Given this list of marker genes KDM4B, PLEK, SEZ6L, PLEKHA4, KIAA2013, CRTC3, ASB10, TLR1, SPATA31E1 (NCBI Gene Id 286234), PHLDB1, RHOT1 (NCBI Gene Id 55288), MAML1 (NCBI Gene Id 9794), IGLJ3, PPP1R15A, SPATA21, GPR17, H2BC11, MARVELD1, MYG1, LINC00242, SLC26A9, PPARD (peroxisome proliferator activated receptor delta), SLC45A1, H2AC11, TMEM33, AHNAK, NECAP2, ARHGAP10, EIF3A, PLEKHG4B, EPHA2, ZNF853, AOC1 (NCBI Gene Id 26), AHNAK2, PKDCC, ARF6, TSFM, MED25, BATF2, NOS3, here is a description of the gene set: from publication Figueroa ME, Lugthart S, Li Y, Erpelinck-Verschueren C, Deng X, Christos PJ, Schifano E, Booth J, van Putten W, Skrabanek L, Campagne F, Mazumdar M, Greally JM, Valk PJ, Löwenberg B, Delwel R, Melnick A (PMID 20060365) studied in species Homo sapiens Cluster 3 of aberrantly hypomethylated genes in blasts from AML (acute myeloid leukemia) patients. We hypothesized that DNA methylation distributes into specific patterns in cancer cells, which reflect critical biological differences. We therefore examined the methylation profiles of 344 patients with acute myeloid leukemia (AML). Clustering of these patients by methylation data segregated patients into 16 groups. Five of these groups defined new AML subtypes that shared no other known feature. In addition, DNA methylation profiles segregated patients with CEBPA aberrations from other subtypes of leukemia, defined four epigenetically distinct forms of AML with NPM1 mutations, and showed that established AML1-ETO, CBFb-MYH11, and PML-RARA leukemia entities are associated with specific methylation profiles. We report a 15 gene methylation classifier predictive of overall survival in an independent patient cohort (p < 0.001, adjusted for known covariates). Human Gene Set: FIGUEROA_AML_METHYLATION_CLUSTER_3_DN